The following is a description of a gene set: Mouse Gene Set: GOBP_ACETATE_ESTER_TRANSPORT studied in species Mus musculus The directed movement of an acetate ester into, out of or within a cell, or between cells, by means of some agent such as a transporter or pore., and this is the list of marker genes: Adora2a, Slc22a4, Tacr2, Slc22a1, Slc18a3, Arl2, Slc44a4, Chrna3, Htr2c, Htr6, Slc17a8, Slc22a2, Cacna1a